Given this list of marker genes WDR74 (WD repeat domain 74), UTP6, PNO1, NSUN4, RRP8, PTBP2, DDX3X (NCBI Gene Id 730543), NPM3, SART1, SF3B5, EIF2S3B, UTP3, LUC7L, RNU5F-1, SLU7, RSL24D1, ISG20L2, SNRPF, PHF5A, PTGES3, SNRPD3, PWP2, ABT1, NOL8, EIF5, PDCD11, EIF2A, GEMIN2, SFSWAP, PA2G4, GEMIN8, LSM2, TFB1M, TRMT61B, RPS5, RPS3A, TSR2, FAU, GREB1L, EIF3B, EIF5B, ATR, NHP2 (NCBI Gene Id 55651), PRP4K, RPS19 (NCBI Gene Id 8378), XRN2, RPS6, BMS1 (NCBI Gene Id 9790), RPL7A, LSM4, RPLP0, EIF4B, UTP23, SETX, DDX47, MPV17L, MALSU1, METTL18, EXOSC9, TMA16, SDE2, RRP9, EIF3M, YJU2, RNU4-1, ERAL1, SF3A3, REXO1L1P, RPS11, GAR1, PAK1IP1, RNU6-1, NGDN, NOP9, RBM5, METTL16, DDX49, DHX37, RPL11, RNVU1-6, PIN4, NUP88, AGO4, PRKRA, MRTO4 (NCBI Gene Id 94394), AAR2, LAS1L, PRPF3, EXOSC4, TRMT2B, SNRPG, NUFIP1, PIH1D1, KRI1, IMP4, GEMIN6, AK6, SNRNP200, MTG1, C1D, RNVU1-3, WDR75, AIRIM, DKC1, RPS15, SRPK2, RBMX2, MIURF, GRWD1, NGRN, RAN, DROSHA, RPSA, URB1, PPAN, RPS7, DDX1, CELF1, DDX28, EXOSC7, DDX51, SRPK1, MPV17L2, RPS27L, RPP38, RNVU1-8, GNL3L, RPL7, GTPBP10, MAK16, RPL10L, PIH1D2, DHX9, SF3A1, RNU6-7, TENT4B, ESF1, DIS3, RNVU1-2A, UTP4, NOB1, SRPK3, EXOSC3, AGO1, POP4, DCAF13, NMD3, RNVU1-1, DHX29, EFL1, EIF3K (eukaryotic translation initiation factor 3 subunit K), RNVU1-14, RIOX2, RPL5, RPS23 (ribosomal protein S23), VCX, CELF2, NIP7 (NCBI Gene Id 51388), UTP25, DDX20, RPS9, U2AF2, PRPF19, RPS25, EIF4A3, RCL1, RNVU1-17, FASTKD2 (NCBI Gene Id 22868), EXOSC6, RRS1, PWP1, RCC1L, COIL, SRSF12, ZCCHC4, DDX39B, EMG1, RPUSD1, TSR1, REXO4, RUVBL1, SART3, AGO3, RPP40, WDR3, MRPS7, SF3B3, METTL15P1, SF3B2, RPLP0P6, RIOK3, RNASEL, DDX42, BUD13, MTG2, FDXACB1, DICER1, MPHOSPH6, DNTTIP2, RRP1, HSP90AA1, SNRPA1, AFG2B, RPSA2, NAF1, DDX56, METTL25B, RPL13A (NCBI Gene Id 94020), MTERF4, DDX52, NOL9, ZNHIT3, SRFBP1, DDX18, SPOUT1, NPM1, RPS8, UTP18, RUVBL2, FBLL1, CUL4B, RPS17 (ribosomal protein S17), MPHOSPH10, TAF12-DT (NCBI Gene Id 105378616), RPS14, NOP53, NOL6, ZNF622, SF1, SMN2, FBL, RPL26L1, TSR3, PRMT7, NOP16, DDX17, SURF6, RNU5B-1 (NCBI Gene Id 26832), TGS1, NOL10, RPS28 (NCBI Gene Id 6234), ERCC2, RPS16, PELP1, LSM6, EXOSC1, FRG1, NOPCHAP1, WDR43, UTP14A, KAT2B, SMN1, TRMT112 (NCBI Gene Id 51504), RNVU1-4, XAB2, RNVU1-19, RPF2, MTREX, EIF3G, MYG1, TAF9, PRKDC, RBFA, TSSC4, MCTS1, BOP1, POP5, EXOSC10, SIRT7, UTP15, RPS27, USP36, YTHDC1, WDR77, EXOSC5, MRM3 (NCBI Gene Id 55178), WEE2-AS1, MYBBP1A, YBEY, ATM, PRPF6, NSUN3, RPS15A, RPP25, PRMT5, SBDS, TFB2M, NOLC1, C1QBP, XPO1, EIF4H, GTF3A, DDX46 (NCBI Gene Id 9879), RPL38, SHQ1, CD2BP2, SF3B1, CELF4, CHD7, HTATSF1, NUDT16, LUC7L3, ZRSR2, SLX9, AATF, NOL3, PRPF8, DIMT1, RPS19BP1, RNU4-2 (NCBI Gene Id 26836), RNU5E-1, ISG20, SNRPE, ABCF1, WDR55, EBNA1BP2, KRR1, EIF3D, RRP1B, ZNF593, GCFC2, EIF3CL, FTSJ3 (NCBI Gene Id 54803), LUC7L2 (NCBI Gene Id 51631), CLNS1A, RPS4X, ZNF658, RRP7A, URB2, POP7, PRPF39 (NCBI Gene Id 81951), SRSF6, DDX21, UTP11, LTV1, KHDC4, DDX23, CLP1, WDR36, RNU11 (RNA, U11 small nuclear), REXO1, SF3B6, RNVU1-7, SNRPD1, NOP56, WDR12, NOM1, USP4, ZNHIT6, AGO2, RPS27A, RRN3, DDX10 (DEAD-box helicase 10), RPP30 (ribonuclease P/MRP subunit p30), RNU5A-1, HEATR3, RBM34, NSA2, EIF3C, CELF5, NOP14 (NCBI Gene Id 8602), TBL3, EIF3I (NCBI Gene Id 8668), MDN1, PES1, SF3A2, DENR, IMP3, RPL35A, RPUSD2, EIF6, EIF3H, NVL, MCTS2, RPL24, DDX27, SUV39H1, YTHDF2, SF3B4, SRSF5, AFG2A, RNU2-1, MRPS2, EIF2S3, METTL15, NOL11, BRIX1, METTL17, RRP15, CRNKL1, CELF6, SNRPD2, EIF2S2, NSUN5, PUF60, NCBP1, RPS21, GTPBP4, RPS13, RIOK1, SNRPB2, RSRP1 (arginine and serine rich protein 1), EIF3J, RPL27, BUD23, USP16, GEMIN7, WBP11, RIOK2, SRSF1, NOP2, RBIS, UTP14C, FCF1, EIF3E (NCBI Gene Id 3646), BYSL, USP39, EIF3F, LYAR, RRP7BP, TXNL4A, NOP10, MRM2, RBM10, SRSF10, RNU1-4, LTO1, CELF3, UTP20, GNL2, LSG1, RPL35, RPS12, MRM1, DHX30 (NCBI Gene Id 22907), RNU6-9, RPF1, NOA1, WDR46 (NCBI Gene Id 9277), RNVU1-15, DDX31, SCAF11, RPUSD4, SNIP1, REXO5, WDR18, GTF2H5, NLE1, SNRPC, NAT10, SRSF9, C1orf131, SNRPB, CDKN2A, PRPF18, RRP36, RPS24, XRCC5, EXOSC2, CUL4A, TARBP2, EIF1AX, EIF2D, MTERF3, NOC4L, DDX54, METTL5, GLUL, MCAT (malonyl-CoA-acyl carrier protein transacylase), CINP, NOL7, HSP90AB1, ADAR (NCBI Gene Id 3427), PRPF31, RPL26, SNU13, GEMIN5, NOP58, STRAP (serine/threonine kinase receptor associated protein), ERI1, SDAD1, HEATR1, RNU5D-1, EIF3L, NOC2L, EXOSC8, GEMIN4, EIF3A, RPL7L1, ISY1, RPL14, RNU4ATAC, PSIP1 (PC4 and SRSF1 interacting protein 1), RNU6ATAC, here is a description of the gene set: studied in species Homo sapiens Human Gene Set: GOBP_RIBONUCLEOPROTEIN_COMPLEX_BIOGENESIS A cellular process that results in the biosynthesis of constituent macromolecules, assembly, and arrangement of constituent parts of a complex containing RNA and proteins. Includes the biosynthesis of the constituent RNA and protein molecules, and those macromolecular modifications that are involved in synthesis or assembly of the ribonucleoprotein complex.